Given this list of marker genes Fgf10 (fibroblast growth factor 10), Sycp2, Klhl10, Shh (sonic hedgehog), Ar, here is a description of the gene set: Mouse Gene Set: GOBP_MALE_ANATOMICAL_STRUCTURE_MORPHOGENESIS The processes by which anatomical structures that are only present in the male organism are generated and organized. species: Mus musculus